The following is a description of a gene set: part of: Response to elevated platelet cytosolic Ca2+ Reactome Pathway: Disinhibition of SNARE formation This event has been computationally inferred from an event that has been demonstrated in another species.<p>The inference is based on the homology mapping from PANTHER. Briefly, reactions for which all involved PhysicalEntities (in input, output and catalyst) have a mapped orthologue/paralogue (for complexes at least 75% of components must have a mapping) are inferred to the other species. studied in species Mus musculus electronically inferred by orthology from the curated human pathway, and this is the list of marker genes: Stx4a, Prkca, Prkcg, Stxbp3